Given this list of marker genes FARP2, STK25, PRDX5, INTS6L, AICDA, PNRC1, E2F2, TXNIP, CHPT1, SELENOM, EVI5, ALDH2, TECR, COPS3, MBTPS1, CALU, FUCA2, UNC50, GRINA, LPIN2 (NCBI Gene Id 9663), PHF3, ZMYND8, ALG2, PAIP2, ING2, DHRS1, PAQR3, VCPIP1, GLB1, TJP2, RAI1, CRK, CUTA, AREL1, PTPRCAP, PPP2R5B, SVIL, PRR3, CYFIP2, PRELID1, ABCA1, ECH1, CLN8, PDK1, GZF1, HCFC2, RDH10, TTC9C, N4BP2, PSRC1, ERO1B, IL18, NCKAP1L (NCK associated protein 1 like), CABP4, DNPEP, EHD4, HIVEP3, BMPR2, RAB11A, RASA4, USP22, TRIM35, UBE2Q2, ODR4, RABGAP1L, ANXA2 (annexin A2), ECI2, ANKRD50, NSF, GATA4, EBP, ATG9A, CDKL2, SLC48A1, CD38, KDM5A, SLC25A24, CTSB, TMCO1, IDH1, GSTT2, ESYT2, IQCB1, TPST1, UHRF2, AP3M1, SELENOP, FILIP1, SYS1, SEPTIN7, DIP2A, CHD2, PDIA6, FAM3C (NCBI Gene Id 10447), LBH, CDK2AP2, MNT, BOD1L1 (NCBI Gene Id 57219), PPP1R15A, HPSE, INPP5K, TMED3, GPCPD1, ERGIC3, HNRNPH3, SDF2, TSPAN14, MCCC2 (methylcrotonyl-CoA carboxylase subunit 2), CCNI, RHOBTB1, DPY19L3, ZNF420, GLMP (NCBI Gene Id 112770), PRRG4, DMWD, FAM78A, UBAC2, EPM2AIP1, TOB1 (NCBI Gene Id 10140), MZB1, TCP11L2, NIPAL3, GALNT2, LMBRD1, MPC2 (NCBI Gene Id 25874), DDX17, CLINT1 (clathrin interactor 1), FAM117A, PLOD2, TAPT1, GLT8D1, TAX1BP1, ZNF790, SNAP23 (synaptosome associated protein 23), FBXO2 (NCBI Gene Id 4930), CHCHD10, GPATCH2 (G-patch domain containing 2), SLC66A2, YIPF4, ENDOU, DERL1, KHDC4, DUSP3, ATG13, COPA, TGFBR2, SLAMF7, XRCC1, SETX (senataxin), GRIP2, TMEM9, ARID3B, COG3, SAMHD1, FLCN, H2BC3, LIMS4, RPN2, TMED2, SLC44A1, NUP210, MLLT3, PSME4, CR1L, THRA, MBNL2, GSK3B, MAP3K1, RAPGEF1, ENPP1, HINT3, ATF2, SCP2, UBN1, ITPR3, SF3B1, FBXO4, CYSTM1, BRAF, PHYHD1, CD5L, SLC35A2, PRDX2, CLK4, ZC3H11A, CMPK1, FOXO3, TMED10, PTGR1, OTUD5, MIA3, CENATAC, SERHL2, RFFL, SMPDL3A, LHPP, NEMP1, TM9SF1, FAM53C, AAK1, here is a description of the gene set: During acute viral infections, naïve CD8+ T cells differentiate into effector CD8+ T cells and, after viral control, into memory CD8+ T cells. Memory CD8+ T cells are highly functional, proliferate rapidly upon reinfection and persist long-term without antigen. In contrast, during chronic infections, CD8+ T cells become “exhausted” and have poor effector function, express multiple inhibitory receptors, possess low proliferative capacity, and cannot persist without antigen. To compare the development of functional memory T cells with poorly functional exhausted T cells, we generated longitudinal transcriptional profiles for each. from publication Doering TA, Crawford A, Angelosanto JM, Paley MA, Ziegler CG, Wherry EJ (PMID 23159438) Genes down-regulated in CD8 T cells: naïve versus exhausted at day 30 chronic infection with LCMV-clone 13. studied in species Homo sapiens Human Gene Set: GSE41867_NAIVE_VS_DAY30_LCMV_CLONE13_EXHAUSTED_CD8_TCELL_DN